Given this list of marker genes Ccr4, Htr2a, V1rg10, Npy6r, Or8g18, Gpr34 (G protein-coupled receptor 34), Gprc5d, Fzd4, Vmn1r70, Oprk1, Or7d11, Or8a1, Or5j3, Gprc5a, Vmn2r27, Vmn2r75, Mrgpra2b, Gpr17, Grm4, Brs3, Chrm5, Vmn2r33, Vmn1r26, Mrgprx1, Gper1, Vmn2r109, Vmn2r91, Vmn1r40, Adgra2, Ccr9, Celsr3, Adrb3, P2ry2, Vmn1r237, Kctd12, Sucnr1, Vmn2r117, Tas2r107, Vmn2r69, Vmn2r88, Nmur2, Vmn1r8, Ptger4, Tas1r1, Gpr150, Vmn2r24, Vmn1r17, Vmn1r190-ps, Vmn2r38, Tas2r114, Vmn2r43, Vmn2r47, Gpr31b, Calcrl, Gpr4 (G protein-coupled receptor 4), Vmn1r19, Or5h17, Glp1r, Vmn2r71, Cxcr3, Adgrf1, Tas2r136, Or5p56, Adgrg6, Vmn1r67, Vmn1r80, Vmn2r32, Opn1sw, Gm14496, Cxcr5, Htr2c, Ltb4r1, Drd2, Gpr37l1, Tas2r105, Vmn1r196, Vmn1r51, Vmn1r41, Or5k16, Gpr132, Vmn2r51, Ramp2, Vmn1r27, Qrfprl, Gpr139, Mrgpra2a, Vmn1r218, Adrb1, Vmn2r20, Gpr62, Ccr2, Vmn2r55 (NCBI Gene Id 100042499), Vmn1r189 (vomeronasal 1 receptor 189), Tacr2, Tas2r134, Vmn1r212, Ccr5, Vmn2r17, Chrm4, Mtnr1a, Vmn1r193, Vmn2r79, Gpr87, Crhr2, Mrgpra6, Vmn2r25, Vmn1r35, Or5p51 (olfactory receptor family 5 subfamily P member 51), Vmn1r33, Or5b21, Tas2r125, Gpr157, Or5t7, Vmn1r16, Vmn2r108, Vmn1r48, Taar8c, Or2b6, Vmn2r59, Vmn2r101, C5ar1, C5ar2, Hrh3, Vmn1r7, Adgrf5, Vmn1r206, Oxgr1, Gpr22, Adgre1, Lgr4, Nmbr, Tas2r144, Cckar, Drd4, Grik3, Gabrb1, Vmn2r114, Taar2, Htr1d, Adgrl4, Vmn1r195, Cysltr1, Bdkrb1, Vmn2r77, Tas2r109, Ccr7, Glp2r, Mrgprg, Tas2r138, Cxcr1, Vmn2r13, Sphk2, Ccr8, Celsr1, Vmn2r102, Vmn2r11, Cx3cr1, Vmn2r92, Fzd8, Gpr20, Adgrf4, Prokr1, Tas2r126, Or4b13, Or3a10, Lpar2, Vmn2r30, P2ry1, Avpr2, Vmn2r67, Htr1b, Or10d1b, Or5t17, Tas2r103, Mrgprb3, Or5p4 (olfactory receptor family 5 subfamily P member 4), Vmn1r210 (NCBI Gene Id 171269), Ackr3, Ptgdr2, Vmn1r191, Taar7e, Vmn1r236, Fzd10, Gipr, Vmn1r89, Fpr-rs3 (formyl peptide receptor, related sequence 3), Vmn2r111, Kctd16, Gpr35, Vmn1r9, Npr3, Vmn1r24, Vmn2r82, Vmn2r130, Mrgpre, Vmn1r214, Or5p69, Vmn2r120 (NCBI Gene Id 224916), Hcar1, Vmn2r5, V1ra8, Tas2r106, Vmn2r44, Ednrb, Or5p76, Vmn2r34, Taar8b, Mrgpra1, Chrm2, Gpr63, Or5h18, Taar1, Vmn2r66, Vmn2r45, Tacr3, Lgr5, Fpr-rs6, Drd1, Tas2r130, Vmn2r68, Vmn2r87, Tas2r143, Lpar3, Vmn2r14 (NCBI Gene Id 671634), Vmn2r106, Ptger1, Vmn1r5, Galr2, Vmn1r83, Slc22a22, Or10h28, Vmn1r231, Hcrtr1, Vmn1r52, Gpr135, Vmn2r95, Galr3, Taar6, Mchr1, Sphk1, Mrgprx2, Or7e178, Taar4, F2rl1, Mrgprb4, S1pr5, Adgre5, Sigmar1, Tas2r102, Vmn1r192, Or5h19, Grm2, Vmn2r42, Tas2r119, Fzd6, Ffar2, Or5p72, Tas2r104, Vmn1r226, Grm3, P2ry13, Gpr21, Vmn1r73, Mrgprb1, Vmn1r230, Gpr158 (NCBI Gene Id 241265), Or8g17, Or8b3, Adgre4, Gpr143, Vmn1r42, Vmn1r208, Vmn1r75, Vmn1r23, Casr, Vmn2r57, Lpar4, Fpr-rs4, Gprc5b, Cmklr2, Kiss1r, Ghrhr, Rxfp4, Qrfpr, Vmn2r40, Adcyap1r1, P2ry10, Cmklr1, Gpr161, Adgrv1, Gpr82, Gpr19, Lpar5, Tas2r135, Gpr88, Gpr6, Vmn1r28, Fpr2, Xcr1, Htr2b, Tas2r121, Npy1r, Gpr183, Or5g25, Gpr25 (NCBI Gene Id 676388), Vmn2r121, Fpr-rs7, Vmn2r84, Vmn2r8, Vmn2r29, Nmur1, Fshr, Or9s13 (NCBI Gene Id 257890), Or5p55, Vmn1r217, Ackr2, S1pr3, Gpr153, Or2c1, Nlrp6, Gpr84, P2ry6, Taar9, Tas2r137, Or2v1, Agtrap, Gpr75, Tmem116, Vmn1r234, Vmn2r22, C3ar1, Crhr1 (corticotropin releasing hormone receptor 1), Tas1r3, Crcp, Gpr45, Vmn1r36, Vmn1r215, Sctr, Ltb4r2, Rrh, Adgrg4, Or5p52, Vmn2r21, Vmn1r74, Sstr5, Ntsr2, Vmn1r43, Vmn1r81 (NCBI Gene Id 171244), Gpr119, Gpr141b, Vmn2r53, Or10d3, Vmn2r35, Cckbr, Rho, Vmn1r220, Sstr3, Mrgprb2, Or5p62, Vmn1r197, Adgrl3 (NCBI Gene Id 74495), Vmn2r80 (NCBI Gene Id 671089), Or6b9, Vmn1r185, Gpr171, Adora2a, Cxcr2, Or6e1, Tas2r123, Adgrl1, Vmn1r200, Vmn2r94, Mtnr1b, F2rl2 (NCBI Gene Id 268688), Adra1a, Adgrd1, Vmn1r225, Gpr179, Or10n1, Lpar6 (lysophosphatidic acid receptor 6), Tas2r131, Mc4r, Vmn1r219, Oprd1 (opioid receptor, delta 1), Tacr1, Ccr1l1, Or5ap2, Gprc6a (G protein-coupled receptor, family C, group 6, member A), P2ry14, Or5p64, Or1j1, Adgrg3, Vmn1r232, Npbwr1, Calcr, Trhr, Vmn1r213, Vmn2r56, Ackr4, Agtr2, Ednra, Kctd8, Vmn2r99, Or4c3d, Vmn1r22, Adgrf3, Sstr2, Hrh1, Gpr15, Npy5r, Vmn2r72 (NCBI Gene Id 637548), Vmn2r65, Grm1, Vmn1r54, Tas1r2, Vmn1r211, Vmn2r36, Gpr156, Htr5a (5-hydroxytryptamine (serotonin) receptor 5A), Vmn1r229, Vmn2r105, Grm5, Vmn1r84, Ccr3, Aplnr, Vmn2r48, Grm6, Adra2c, S1pr1, Or7a40, Gpr27, Hrh4, Or5p68, Gpr165, Adgrf2, Tas2r139, Hrh2, Or5k17, Gpr33, Vmn2r115 (vomeronasal 2, receptor 115), Taar3, Pth2r, Vmn2r49, Tbxa2r, Inpp5k, Hpgd, Vmn2r97, Vmn2r63, Vmn2r107 (NCBI Gene Id 22312), Or5p70, Mrgprh, Vmn1r37, P2ry10b, Adgrb3, Adora3, Adgrg5, Or5d20-ps1, Oprl1, Ramp1, Hcar2, Mrgprb5, Cxcr4, Tas2r129, Vmn2r54, Vmn2r28, Vmn2r98, Gpr85, Vmn2r15, Rxfp2, Drd5, Rxfp3, Ffar4, Vmn2r70, Fzd7, Hcrtr2, Vipr1, Vmn2r12, Cnr2, Or8u3-ps, Vmn1r205, F2r, Vmn1r235, Vmn2r74, Vmn1r30 (NCBI Gene Id 171195), Or5p53, Htr1a, Vmn2r39, Gpr37, Smo, Gpbar1, Or5an6, Vmn2r52, Vmn1r228, Or5g29, Ccrl2, Or8b8, Ccr6, Htr7, Taar7b, Ccr1, Or10j5, Vmn1r202, Vmn2r26, Gpr68, Gpr162, Vmn1r78, Or5g26, Gpr50, Gpr173, Sstr1 (NCBI Gene Id 20605), Or1j21, Ffar1 (NCBI Gene Id 233081), Vmn2r61, Adra1d, Esr1, Npy2r, Lpar1, Vmn1r21, Vmn2r58, Tas2r140, Vmn2r1, Gpr149, Kctd12b, Adgrl2, Or6z7, Vmn2r19, Gpr65, Uts2r, Gabbr1, Vmn1r53, Npffr1, Fzd2, Opn3, Or4m1, Fzd1, Npffr2, Mrgpra9, Gpr61, Npsr1, Gpr3 (NCBI Gene Id 14748), Avpr1a, Ptafr, Vmn2r10, Fpr1, Or5t9, Ntsr1, Or5p73, Vmn1r45, Gpr142, Vmn1r38, Or5p59, Adgra1, Adrb2, Grid1, Vmn1r198, Adora2b, Vmn1r82, Ptger3, Vmn1r201, Or51e2, Or5g9, Grpr, Trhr2, Vmn2r60, Or5p57, Or2a7, Mc3r, Taar7f, Adora1 (adenosine A1 receptor), Adra2a, Vmn1r216, Vmn2r6, Adra2b, Vmn2r129, Adgrg7, Vmn2r113, Bdkrb2, Gcgr, Vmn2r112, Slc39a9, Grm7, Vmn1r87, Gpr146, Gpr176, Or5p54, Or5ar1, Fzd5, Gm5127, Adgrb1, Ffar3, Gprc5c, Vmn2r124, Vmn2r93, Vmn2r86, Or9g19, Agtr1a, Celsr2, Vmn2r118, Mas1, Vmn2r116, Gpr52, Gpr182, Vmn1r6, Vmn2r100, Avpr1b, Chrm1, P2ry4, Tpra1, Mrgpra4 (NCBI Gene Id 269922), Or5p80, Cysltr2, Gpr55, Fzd9, Sstr4, Lhcgr, Vmn1r222, Vmn2r96, S1pr2, Grm8, Vmn1r47, Ccr10, Vmn1r76, Rorb, Gpr12, Adgrb2, Cnr1, Tas2r118, Or2y1b, Or5p6 (olfactory receptor family 5 subfamily P member 6), Opn1mw, Gpr160, Opn5, Vmn1r18, Vmn2r2, Or5p1, Taar7d, Vmn1r233, Vmn2r90, Adgrg1, Vmn2r104, F2rl3 (NCBI Gene Id 14065), Mc1r, Gnrhr, Gabbr2 (gamma-aminobutyric acid type B receptor subunit 2), Gpr101, Vmn1r49, Vmn2r7, Or7a42, Vmn2r78, Ramp3, Or1e16, Gpr39, Vmn1r50 (vomeronasal 1 receptor 50), Or5t18, Prokr2, Mc5r, Ptger2, Or8c8, Tas2r117, S1pr4, Vmn2r50, Fpr3, Vmn2r16, Agtr1b, Gpr83, Gpr152, Taar8a, Or5p50, Vmn1r227, Or5p58, Gpr26, Rxfp1, Vmn1r188, Or8u9, Htr5b, Vmn2r37, Htr1f, P2ry12, Vmn2r4, Rgr, Vmn2r85, Tas2r116, Htr6, Taar7a, Vmn2r62, Vmn1r44, Lgr6, Gpr174, Vipr2, Ptgdr, Vmn1r199, Npy4r, Mrgpra3, Prlhr, Or5p67, Vmn2r110, Vmn2r76 (vomeronasal 2, receptor 76), Adra1b (adrenergic receptor, alpha 1b), Tas2r108, Opn4, Vmn1r46, Vmn2r3, Vmn1r66, Or5p60, Or8g50, Gal, Fzd3, Vmn2r18 (vomeronasal 2, receptor 18), Or56b34, Vmn2r31, Or5m5, Oxtr, Vmn1r4 (vomeronasal 1 receptor 4), Or5p79, Tas2r124, Tas2r110, Taar5, Adgra3, Ackr1, Adgrg2, Tm2d1, Chrm3, Vmn2r41, Tshr, Vmn2r83, Vmn2r81, Ptgir, Mrgprf, Vmn1r203, Vmn2r9, Gpr141, Vmn2r103, Mrgprd, Tas2r113, Or5p66, Ppard, Vmn2r23, Ptgfr, Cxcr6, Gpr151, Drd3, Vmn1r32, Ghsr, Oprm1, Mrgprb8, Gpr18, Htr4, Tas2r120, Or5p81, Vmn2r73, Or10p22, Galr1, Pth1r, Mc2r, Pgr15l, Or4e2, Or1m1, here is a description of the gene set: Combining with an extracellular signal and transmitting the signal across the membrane by activating an associated G-protein; promotes the exchange of GDP for GTP on the alpha subunit of a heterotrimeric G-protein complex. Mouse Gene Set: GOMF_G_PROTEIN_COUPLED_RECEPTOR_ACTIVITY studied in species Mus musculus